The following is a description of a gene set: species: Homo sapiens Human Gene Set: GOBP_RHOMBOMERE_DEVELOPMENT The process whose specific outcome is the progression of the rhombomere over time, from its formation to the mature structure. Rhombomeres are transverse segments of the developing rhombencephalon. Rhombomeres are lineage restricted, express different genes from one another, and adopt different developmental fates., and this is the list of marker genes: MAFB, HOXB1, GBX2 (gastrulation brain homeobox 2), HOXA2, EGR2, HOXB2, HOXB3